Given this list of marker genes ACOX3 (acyl-CoA oxidase 3, pristanoyl), ARHGAP44, ZFR, PMS2P5, SEPTIN7, LINC01312, HOXA11, TRIM47, KALRN, TMEM95, DDX17, GBX2, BTK, TUT1, MBNL1, RBM14, CDC37L1, PIK3R1, ARF3, NTF4, LHX6, ERBB4 (erb-b2 receptor tyrosine kinase 4), PPP1R16B, BDNF, HOXB6, TIAL1, SETD2, SREBF1, BMP5 (bone morphogenetic protein 5), PCSK2, TCEANC2, ASXL1, CCND2, ELMO1, SCN2A, HSDL2, POLA1, GARIN3, TLX2, NFATC2 (nuclear factor of activated T cells 2), OXA1L, SYNCRIP, BCL6, WNT10A, STAG3L4, TRAF6, PDK4, GJA5, GLRA2, AP1G2, MAT1A (methionine adenosyltransferase 1A), RAB37, PATZ1, SSBP3, SP110, CYP46A1, GFAP, SPTBN2, DYRK2 (dual specificity tyrosine phosphorylation regulated kinase 2), DDX25, EMP1, MZF1, CACNB2, BCL2L1, KIAA0825, FZD6, KLF9, NCKAP5, ATOH8, DSG1, GABPA, TENM3-AS1, CNBD2, KIF24, PRDM13, BTRC, GRID2, ENPP2, FOXA3, ANKZF1, TAL1, DRC7 (NCBI Gene Id 84229), ZNF384, LAMA1, FAM90A1, SDC1, DCUN1D3, RUNX1, SOCS2, CREBRF, KCNJ8, IL1RN, CEP55, KITLG, RARA, CITED4, TMEM59, PTCH1, LRRN3, DARS1, SNX18, ZNF184, GPRC5C, GABRB1, OPN3, STARD3, PCDH9, GSN, CHD2, SYMPK, GRAMD1C, FOXP1, IPO11 (NCBI Gene Id 51194), CCDC28A, ZNF689, SMC1A, TLCD5, LYRM1, CREM, MGRN1, VIP, ATF4, NR4A3, PILRB, ATP5PF, PTPN21, MBNL3, IL9, HNF4G, ZNF180, EPHX4 (epoxide hydrolase 4), KLF4, PALS2, STC1, IRF2BP1, ARL4A, FOS, OBSCN, POU6F2, RBFOX1, SRPX, MITF, ZNF423, here is a description of the gene set: Genes having at least one occurrence of the motif TTCCNRGAANNNNNNTTCCNNGRR in the regions spanning 4 kb centered on their transcription starting sites. This matches the STAT5A transcription factor binding site V$STAT5A_02 (v7.4 TRANSFAC). species: Homo sapiens Human Gene Set: STAT5A_02